The following is a description of a gene set: species: Mus musculus from publication Chen Y, Wang X (PMID 31504780) Mouse Gene Set: MIR_433_5P Genes predicted to be targets of miRBase v22 microRNA mmu_miR_433_5p in miRDB v6.0 with MirTarget v4 prediction scores > 80 (high confidence targets)., and this is the list of marker genes: Zfhx4, Mbtps1, Smad3, Arpp19, Patj, Frmd4b, Igsf10